The following is a description of a gene set: Arterial thrombosis Human Gene Set: HP_ARTERIAL_THROMBOSIS The formation of a blood clot inside an artery. studied in species Homo sapiens, and this is the list of marker genes: F2, ERAP1, FCGR2C, IL12A-AS1, STAT4, CALR, THPO, MEFV, PIGA, IL12A, CBS (cystathionine beta-synthase), HLA-B, PROS1, MPL, UBAC2, KLRC4, C4A, HLA-DRB1, TET2, PTPN22, TLR4, IL10, TP53, SERPINC1, SH2B3, MYH7, P4HA2, JAK2, IL23R, IFNGR1, AKT1, FAS, CCR1